Given this list of marker genes GLRX, APOL6, ISG20, OASL, GBP2, GSTK1, KIF2A, METTL3, APOL2, BACH1, HIF1A, ITM2B, RBCK1, GSAP, FLT3LG (NCBI Gene Id 2323), CD47, PMAIP1, RBMS1, SQOR, TDP2, CD74, OAS2, ADAP1, C5orf15, SOD2, CXCL11, RTP4, PSMA4, STAT3, FAM111A, GGCX, HEG1, LEPROTL1, SLC15A3, C1R, LARS2, AK4, POLI, POU5F1B, HLA-A, IFIT2, BCL2L13 (NCBI Gene Id 25779), KLF6, IFI44L, MREG, SLC25A22, IFIH1, CDK18, IFIT3, HK2, E2F5, BTN3A1, NBN, DENND5A, IL4R, HLA-C, PCLO, BTN3A2, PLSCR4, BST2, RHBDF2, SAMHD1, DRAM1, DPYD, HCP5, IRF8, TMEM140, CLUHP3, HLA-E, USO1 (USO1 vesicle transport factor), SEMA3F, RNF19B, NAMPT, TFG, TAP1, SERPING1, TRIM31, PARP3, UBA7, MSRB1, CTSS, IFI30, ST8SIA4, TNFAIP3, IFI35, CD38, HLA-F, TRIM38, CCDC68, MCL1, CXCL10, LPIN2, CREM, TRIM21, IL32, CFH, LTBR, SELENOP, TRAFD1 (TRAF-type zinc finger domain containing 1), ACSL3, TRIM22, OPTN, PSMB8, COQ10B, RASGRP3, SLC25A28 (solute carrier family 25 member 28), ATP10D, RUBCN, ACKR4, LXN, CFB, IFNGR1, RNF114, CYLD, GUK1, SOCS1, C1S, ZFP36, CASP7, STAT2, STS, ADPGK, USP15, TNFRSF1B, UBE2L6, DOCK4, BTN3A3, IL15RA, ZNF22, PSMA6, FST, ERLIN1, ACTN2, NMI, CALCOCO2, TAPBPL, IGFBP3, RIGI, IDO1, IL15, CEACAM1, PWAR5, GOLGA1, APOL1, PSMB9 (proteasome 20S subunit beta 9), SP140L, IRF1, CD40, RMI1, PSMB10, NUP107, BATF3, DOP1A, CXCL2, WARS1, NDUFA9, LAMP3, MAFF, ZNF302 (NCBI Gene Id 82167), LAP3, MTMR14, PLAUR, TGM2, ASPM, PLAAT4, APOL3, GBP1 (guanylate binding protein 1), PLEKHF2, TLR3, CLEC2B, C3, HLA-K, NFE2L3, TMEM59, WDR25, PSME1, XPO6, RBM7, SPATS2L, BMAL2, SLC7A2, CCL5, BCO1, IGFLR1, CASP1, SP110, TAP2, TOP1, JAK2, TNFSF10, MAX, AK2, HK1, MX2 (NCBI Gene Id 4600), DUSP5, SECTM1, NECAP1, HLA-G, FAS, here is a description of the gene set: studied in species Homo sapiens Human Gene Set: GSE42021_CD24HI_VS_CD24LOW_TCONV_THYMUS_DN from publication Toker A, Engelbert D, Garg G, Polansky JK, Floess S, Miyao T, Baron U, Düber S, Geffers R, Giehr P, Schallenberg S, Kretschmer K, Olek S, Walter J, Weiss S, Hori S, Hamann A, Huehn J (PMID 23420886) Genes down-regulated in thymic T conv: CD24 high versus CD24 low. We investigated at which stage of maturation commitment to a stable Foxp3-expressing phenotype takes place. We assessed stability of Foxp3 expression in thymic Foxp3+ Treg subsets of different maturity, defined by CD24 expression. Next we compared gene expression profiles of Foxp3+ Treg subsets (+) of different maturity (24lo, 24int, 24hi) and could identify a set of genes that were specifically up or downregulated in Foxp3+ Tregs, but not in Foxp3- conventional T cells, in a maturation-dependent manner.